Given this list of marker genes THSD1, HSPD1P16, CARD10, RAMP3, MADCAM1, ADCY4, STAB2, NOS3, SOX7-AS1, ENSG00000266767, SYBU, CEACAM1, NOTCH4, TIE1, SLC5A4, ULBP2, ASIC2, VIP, LINC02196, FAM167B, STC2, GABRD, NR5A2, RP1, SP6, MMP25, CYP26B1, ABHD12B, GPR4, FAM110D (family with sequence similarity 110 member D), MSX1, TM4SF18-AS1, GPR182, EPHB4, SSUH2, SPAAR, PCAT19, PPP1R13B, DIPK2B, ESM1, CASP4LP, FCN3, BDKRB2 (bradykinin receptor B2), ENSG00000248636, BCL6B, MAPK11, LINC02147, SELE, SHE, ANKRD36BP2, CALCRL, CLEC14A, SOX17, TCF15, NOS2, ROCK1P1, MALL, DISC1FP1, CDH5, GIPC3, TPT1P15, RAET1G, TCIM, MIR126, KANK3, PREX2, TBC1D21, GUCY1B2, EFCC1, CLVS1, LINC02384, NTS, KCNIP4, ENSG00000255462, GALNT15, CLEC1A, LINC02880, ECSCR, SV2B (synaptic vesicle glycoprotein 2B), DYSF, LHX6, ADGRF5, ARHGEF15, LRRC77P, ULBP1, PIWIL1, PRND, C2CD4B, RFX8, NRP2, MMRN2, FUT1, ENSG00000241525, KCNC4 (potassium voltage-gated channel subfamily C member 4), CASP12, SHANK3, ENSG00000253348, PTPRB, GPM6A, ADGRL4 (NCBI Gene Id 64123), LINC02487, CIMAP1D, EXOC3L1, TMEM88, QRFPR (NCBI Gene Id 84109), RBP5, HAFML, here is a description of the gene set: studied in species Homo sapiens from publication Cao J, O'Day DR, Pliner HA, Kingsley PD, Deng M, Daza RM, Zager MA, Aldinger KA, Blecher-Gonen R, Zhang F, Spielmann M, Palis J, Doherty D, Steemers FJ, Glass IA, Trapnell C, Shendure J (PMID 33184181) Marker genes curated from the annotated cluster as represented in the Descartes Human Gene Expression During Development database. The gene expression program underlying the specification of human cell types is of fundamental interest. The study authors generated human cell atlases of gene expression and chromatin accessibility in fetal tissues. For gene expression, the study authors applied three-level combinatorial indexing to >110 samples representing 15 organs, ultimately profiling ~4 million single cells. The study authors leveraged the literature and other atlases to identify and annotate hundreds of cell types and subtypes, both within and across tissues. Our analyses focused on organ-specific specializations of broadly distributed cell types (such as blood, endothelial, and epithelial), sites of fetal erythropoiesis (which notably included the adrenal gland), and integration with mouse developmental atlases (such as conserved specification of blood cells). These data represent a rich resource for the exploration of in vivo human gene expression in diverse tissues and cell types. Human Gene Set: DESCARTES_FETAL_KIDNEY_VASCULAR_ENDOTHELIAL_CELLS